Given this list of marker genes Gjd2, Gja10, Gjc1, Panx2, Panx1, here is a description of the gene set: species: Mus musculus Electric Transmission Across Gap Junctions Mouse Gene Set: REACTOME_ELECTRIC_TRANSMISSION_ACROSS_GAP_JUNCTIONS